Given this list of marker genes SLC38A4, SLC38A1, SLC3A2, SLC7A8, SLC36A3 (solute carrier family 36 member 3), SLC38A2, SLC6A14, SLC7A5, SLC36A2, SLC6A17, SLC38A3, SLC36A4, SFXN1, SLC38A5, SLC6A6, SLC1A4 (solute carrier family 1 member 4), SLC36A1, SLC7A10, here is a description of the gene set: The directed movement of alanine, 2-aminopropanoic acid, into, out of or within a cell, or between cells, by means of some agent such as a transporter or pore. Human Gene Set: GOBP_ALANINE_TRANSPORT studied in species Homo sapiens